The following is a description of a gene set: species: Mus musculus Mouse Gene Set: GOBP_NEGATIVE_REGULATION_OF_MACROPHAGE_DIFFERENTIATION Any process that stops, prevents, or reduces the frequency, rate or extent of macrophage differentiation., and this is the list of marker genes: Adipoq, Thoc5, C1qc, Ptpn2, Gata2, Zbtb46, Qki